Given this list of marker genes Pla2g4a, Rab18, Dync1h1, Tuba1a, Capza2, Tubb4a, Dctn3, Dynll1, Dync1i1, Capza3, Rab3gap2, Tuba3b, Tubal3, Agpat3, Rab6a, Tuba3a, Actr1a, Tubb2a, Dctn6, Dctn2, Dctn4, Tubb1, Tuba4a, Tuba1c, Dync1li2, Rab6b, Pla2g6, Actr10, Pafah1b1, Bicd1, Tubb3, Capzb, Dctn1, Galnt1, Tubb4b, Tubb6, Tuba1b, Pafah1b3, Pafah1b2, Dync1li1, Rab3gap1, Dync1i2, Tubb2b (tubulin, beta 2B class IIB), Dynll2, Bicd2 (BICD cargo adaptor 2), Galnt2, Dctn5, Tuba8, here is a description of the gene set: Mouse Gene Set: REACTOME_COPI_INDEPENDENT_GOLGI_TO_ER_RETROGRADE_TRAFFIC studied in species Mus musculus COPI-independent Golgi-to-ER retrograde traffic